The following is a description of a gene set: Genes down-regulated in macrophage differentiated by: CSF1 versus CSF1 and IL27. from publication Swaminathan S, Hu X, Zheng X, Kriga Y, Shetty J, Zhao Y, Stephens R, Tran B, Baseler MW, Yang J, Lempicki RA, Huang D, Lane HC, Imamichi T (PMID 23535375) species: Homo sapiens Human Gene Set: GSE44955_MCSF_VS_MCSF_AND_IL27_STIM_MACROPHAGE_DN In this study, we hypothesized that IL-27 could induce the expression of novel miRNAs in macrophages which may have functional relevance in terms of anti-viral activity. In this study, primary monocytes were differentiated into macrophages using M-CSF (M-Mac) or with a combination of M-CSF and IL-27 (I-Mac) for seven days. Following this, total RNA was extracted from these cells and deep sequencing was performed, in parallel with gene expression microarrays. Using the novel miRNA discovery software, miRDeep, seven novel miRNAs were discovered in the macrophages, four of which were expressed higher in I-Mac (miRNAs 2.1, 8.1, 9.1 and 14.2) whilst three were detected in both M-Mac and I-Mac (miRNAs 9.3, 13.6 and 15.8). The expression of six of the seven novel miRNAs was highly correlated with qRT-PCR using specific primer/probes designed for the novel miRNAs. Gene expression microarray further demonstrated that a number of genes were potentially targeted by these differentially expressed novel miRNAs., and this is the list of marker genes: IFFO2, PRRC2A, RAB33A, UBE2J2, AQP3, SELPLG, LOXHD1, SLC27A3, ITGA2B, OS9, INTS3, CCDC88B, PHTF2, SCARF1, PHLPP1, FKBP5, CELF1, SCGB2A1, CD1A, GOLGA8A, RBM10, BMP8B, C1QTNF12, SLC39A6, ZNF641, RNF144B, PRSS3, PALD1, DIRAS1, FAM110A, PPP1R9B, GLIPR2, EIF3D, BANF1, IGFBP7, KCTD10, ETS1, TTC9C, BLOC1S6, MTFP1, CHID1, KLHL3, SLC25A1, NMB, LINC01093, TUBB4B, GPR20 (G protein-coupled receptor 20), PON2, RARA, ZFP3, MRTFA, LDHA, SUFU, STAC, GNB2, RPRD1A, IL1RAP, CNPPD1, ZC3HC1, NPDC1, CST5, TJP2, CFLAR, REEP6, BCL6, VCL, GPD1L, NAGPA, DENND4B, CTNNA1, PCOLCE, FHOD1, RAB7A, NPR1, SSR3, ASB8, PODXL, AP2S1, STARD10, KATNB1, TUBA4A, ANO7L1, S100A5, PROP1, CATSPERZ, BRD9, SHCBP1, NAAA, CDR2L, KCTD17, CAPN2 (NCBI Gene Id 824), ATP11B, TP53I11, CHMP2A (NCBI Gene Id 27243), SYT6, ACTR3B, RCHY1, DYNC1LI1, CST4 (NCBI Gene Id 1472), ZNF562 (NCBI Gene Id 54811), PHETA1, EIF4G1, KCNK6, DIAPH1, STARD7, DHRS12, ZRSR2, SBF1, SLC35C1, SCFD2, ADORA2B, APEX2, SH3BP4, LGALS1, SOBP, KLHDC3, SNAPIN, ABL2, MRPL34, SYNE3, SMG7, MTUS1, LYRM4, DAG1, TBC1D5, RDH13, STK17B, MAD1L1, TMEM270, KIAA1671, WDFY4 (NCBI Gene Id 57705), PURPL, SHC1, MEGF8, PIP4P1, LY6E, FLOT2, NCOR2, STAT6, LRRC8C, PXDC1, GTPBP8, OPRD1, HELZ2, PLCB3, CRB2, IL2RG (NCBI Gene Id 3561), EHD4, MVB12B, CAP1, CABIN1, ESRRA, PLEC, MAPK7, CHRAC1, MAP4K1, EIF4E2, AKT1, MYLIP, GIT1, ROGDI, C18orf21, KIAA0040, ABRAXAS2, INPP5D, MPZL3, SERPINF2, ACVR2A, CALM1, ZNF555, ETV2, PRPS1, GUCA1A, CASP2, PKM, BBOF1, NEU4, ZDHHC20, UBN1, CMTM8, NRDC, IQCE, IPCEF1, CEP112, VASP, MAN1C1, HOXA4, C1orf162, TREML2, ECSIT, ZNF2, IGDCC3, TTPA, CMPK2, SLC9A5, DGKZ, CST3, DOK1, CCDC78